Given this list of marker genes Cd300lf, Narf, Gm11747, Btbd17, Gm11762, Hexd, Mir338, Slc39a11, Gm11793, Septin9 (septin 9), Snord1a (NCBI Gene Id 100216538), Rhbdf2, Uts2r, Oxld1, 0610009L18Rik, Grb2, Gm11677, Zfp750, Syngr2, Slc25a10, Lgals3bp, Sgsh, Mtnap1, Armc7, Cygb, Llgl2, Slc38a10, Unk, Gm11704, Mgat5b, Mir6516, Rpl36-ps1, Otop3, Aspscr1, Rab37, Smim5, Ogfod3, Trim65, Rnf157, Cog1, 2610035D17Rik, Sphk1, Cdk3, Usp36, Gm11691, Gcgr, Mxra7, Pde6g, Mfsd11, Galk1 (galactokinase 1), Mrpl12, Gm11679, Gm22152, Gm11733, Gm11676, Slc26a11, Rptoros, Ube2o, Dus1l, Galr2, Lrrc45 (NCBI Gene Id 217366), 1700001J04Rik, Gm11736, Tmc6, A930037H05Rik, Gm11755, Gm11750, Cbx4, P4hb, Gm11734, Mir6933 (NCBI Gene Id 102466768), Mir6936, Gm26413, Cbx8, Slc25a19, St6galnac2, Gm11702, Cd300c, Fscn2, Fasn, Eif4a3, Gm11692, Srp68, Acox1 (acyl-Coenzyme A oxidase 1, palmitoyl), Gm11723, 1700025D23Rik, Cd300ld, Atp5pd, Wbp2, Gm11789, BC018473, Itgb4, Sectm1b, H3f3b, Smim6, BC006965, Gm12589, Gm25364, Fbf1, Jpt1, St6galnac1, 2900052L18Rik, Card14, Metrnl, Mcrip1, Nptx1, Rac3, Mettl23, Cdc42ep4, Cant1, Mir6935, Gm12586 (predicted gene 12586, NCBI Gene Id 108167874), Cd300ld3, Mrpl58, Aanat, Npb (neuropeptide B), Ccdc137, Bahcc1, Mafg, Gm11738, Tex19.1, Gm11682, Kcnj2, Cd300c2, Fads6, Cd300e, Rptor, Cd300ld5, Ptchd3, Tepsin, Gm11695, Cep295nl (NCBI Gene Id 58251), Cd300ld2, Mir7236, Cdr2l, Evpl, Wdr45b, Tmc8, Qrich2, Alyref, Kif19a, Sectm1a, Sirt7, 6030468B19Rik, Notumos, Cenpx, Gprc5c, Cd300ld4, Nherf1, Gm11790, Sap30bp, C1qtnf1, Rab40b, Gm11690, Mrpl38, Gps1, Gm11754, 1700092K14Rik (RIKEN cDNA 1700092K14 gene), Tsen54, Dnai2, Ttyh2, Cpsf4l, Ict1os, Gm23699, Nploc4, Tbc1d16, Ccdc57, Slc16a5, Rnf213, Hid1, Ush1g, 2900041M22Rik, Gm11735, Cbx2, Gm11732, Mir3065, Endov, B3gntl1, Gm11728, Rpl38, Prpsap1, Hmga1b, Gm34418, Fdxr, Dnah17, Cybc1, Recql5, Gm11680 (predicted gene 11680), Srsf2, Sap30bpos, Cbr2, Sumo2, Tbcd (NCBI Gene Id 77213), Cd300a, Chmp6, Tspan10, Gm12591, Unc13d, Foxj1, Cd7, Gpr142, Gm11681, Snord1c, Ubald2, Jmjd6, Nup85, Sstr2, Gm11699, Gm11703, Prcd, 4932435O22Rik, Gm11675, Dcxr, Nat9, Mif4gd, Mir3968, Socs3, Engase, Enpp7, Tk1, Snord1b, Rfng, Gm11772, Mir5621, Sox9, Aatk (apoptosis-associated tyrosine kinase), Cd300lb, Gm11689, Baiap2, Fn3k, Gm11694, Kctd2, 4732490B19Rik, Foxk2 (forkhead box K2), Gm11725, Gm11767 (predicted gene 11767), Arhgdia, Nt5c, Myadml2, Reno1, Myo15b, Tmem235, Slc16a3, Timp2, Gm11788, Sec14l1, Cyth1, Trim47, Cep131, Mir6934, Pgs1, Gm8624, Gm3807, Rps11-ps2, Notum, Gm11769, Csnk1d, Pcyt2, Vcf1, Gm12587, Grin2c, Fn3krp, Gm11753, Gaa (NCBI Gene Id 319889), Arl16, Ccdc40, Gm11775, 4933434M16Rik (NCBI Gene Id 74950), Tmem94, Exoc7, Tex19.2, Snhg16, Kcnj16, Ndufaf8, Sdk2, Tnrc6c (trinucleotide repeat containing 6C), Snhg20, Tmem104, Gm11729, Afmid, Rbfox3, Tha1, Gm11730, Trim80, Pycr1, Birc5, Mir1932, Otop2, Faap100, Hgs, Gga3, Ten1, Gm11771, Anapc11, Mrps7, Actg1, Caskin2, Ppp1r27, here is a description of the gene set: Mouse Gene Set: chr11E2 species: Mus musculus